Given this list of marker genes THOC2, GRAMD2B, KREMEN1, NOSTRIN, RNF19A (ring finger protein 19A, RBR E3 ubiquitin protein ligase), TRAF5, GPR160, RHBDF1, GORASP1, FOXP1, GASK1B, RICTOR (RPTOR independent companion of MTOR complex 2), SLC44A2 (solute carrier family 44 member 2 (CTL2 blood group)), MTURN, HEBP2, RAB22A, KLF3, NINJ2-AS1, PAIP1, HACD3, EEA1, NDFIP1, CLTC, KLF9, MFAP3L, KIAA1671 (KIAA1671), HTR7P1, IGSF3, CCNE1, BLNK (NCBI Gene Id 29760), FAM110C, SPRED2, ATP6V1G1, GALNT3, CHMP3, RNF103, ATP2B1, INHBB, BIK, OLFML2B, CORO2A, B3GNT2, VPS13B, CAB39L, TRAM2, RAI2, PCYT1A, C1orf115, ARRB1, DYNLL2, KRAS, TWSG1, TMEM45B (transmembrane protein 45B), SYNJ2, NUCB2, GREB1L, PRR15L, FZD4, RASD1, CPNE3, ERBB4, ZNF704, YIPF1, CAP1, GPC1-AS1, GSN, PPM1A, UTRN, BCAM (NCBI Gene Id 4455), TBC1D15 (NCBI Gene Id 64786), QKI, ORMDL1, FAM114A1, TMEM199, COL28A1, KLF7 (NCBI Gene Id 8609), VMP1, EFR3A, ATP2C2 (NCBI Gene Id 9914), STK38L, EPB41L4A, FGF13, LDLRAP1, DOP1B (DOP1 leucine zipper like protein B), ACADSB, GATA3-AS1, SAR1B, RFTN1, PAX9, GATA6, CCNYL1, PKD2, TMEM245, TTC6, FBXO25, BRWD1, CERK, ZBTB21, ZC2HC1A, SOWAHC (sosondowah ankyrin repeat domain family member C), MEF2A, ACSL1, HCAR3, FAM219B, NCEH1, GRAMD4, RAP1GAP2, DOCK11, UGDH (NCBI Gene Id 7358), HSPA2 (heat shock protein family A (Hsp70) member 2), MIPEP, PDZD2, MYO1B, ELL2, PPP2CB, PTPRJ, TJP2, CRISP3, OR7E14P, SH3D19, PSMD6, TMF1, EPS15, MAFK, TMEM135, SLC12A2, SMYD3, GTF3C1, TACC1, MALT1, CALU (calumenin), PBX1, ATP8A1 (NCBI Gene Id 10396), SYCP2, MIOS, ZNF487, MYH9, WSB2, WIPI1, YPEL3, DRAIC, KIF13B, TSPAN13, TMEM41B, PLLP, MTMR12, ATP2B1-AS1, BCDIN3D, FNTA, PLEKHA7, RHOU, PARM1, COPB2, MB, PHLDA3, ST3GAL4, ARL4C, FNBP1 (NCBI Gene Id 23048), DSCR8, CCDC160, SLC9A7, ERBB2, REEP1, USP16, EMP1, LRPAP1, TMEM41A, PLEKHS1, SMIM14, RAB20, EML1, SELENOM, TACSTD2, MIOS-DT, DRAM1, MAPK6, TBC1D13, NAXD, PHF20L1, GALNT10, FAR2P2, POGLUT3, TCF4 (NCBI Gene Id 6925), LSS, AGR2, OCLN, ULBP2, WASHC5, MAL2, CDKL5, AKTIP, SLC25A16, SGSM2, ATP2A3, SH3BP4, CEACAM6, PALM3, CDS1, SERHL2, FZD5, IDH2, TNFAIP1 (NCBI Gene Id 7126), SPAG1, LRATD2, TNFRSF10B (TNF receptor superfamily member 10b), CTNND1, SCCPDH, GOLGA3, ZNF275, S100A13, ALCAM, GAREM1, TC2N (NCBI Gene Id 123036), NATD1, TIMP3, IER2, SLC41A2, TRIB3, HOXA10, FAM20C, LIMA1, C3orf70, LITAF, DHCR24, FHIP2A, TMCO3, CHFR, GALNT7, NACC2 (NACC family member 2), GOLGA7, RAB1A, SMAP2, COPZ2, FAM234B, PIP4K2C, INPP1, NIPSNAP3B, FERRY3, RIPOR3, ABHD17C, ZDHHC7, CAB39, PCOTH, ZDHHC4, MFSD6, LFNG, PPP1CB, MID2, RFK, PHLDB2, ZNF827, IL1R1, ZNF823, ALDH3B2, MBNL1, TRAK1, SGSM1, EPB41L4B, TMEM59, FAM241A, LIMK2, MPZL2, KLHL7, DSTNP2, ARF4, RAB11A, CARD14, ST3GAL1, PI4K2B, CTNNB1, RPRM, PRICKLE2, CCDC68, ADAM9, ICA1, WLS, APELA, RIN2, CLDN4, RASL11B, GLTP, EPAS1, KCNMA1, ATP8B1, DYRK2, CDH3, SEL1L, CASP3, FGF12, SOCS6, TMTC3, NEBL, FLVCR2, LIMCH1, APLP2, RNF11, RIOK3, NXPH1, ZNF432, PGPEP1, MUC1, SEC22B, RAB2A, MIR34AHG, SQOR, ACKR3, GAB1, ASAH1, PDE8A, ENPP1, SLC9A1, DDAH2, HIP1R, GABBR2, TRIM62, FHOD1, TRAFD1, BEX4 (NCBI Gene Id 56271), BAMBI, KDELR2, COBLL1, PTPN13, LARP6, PRRT3, VPS13D, THBS1, STX12, DBI, AQP3, TMEM50B, PTGFRN, IKBKB, EHD1, MATN3, GUCD1, PPFIBP2, RUBCN, PSD3, PLEKHF2, LGALSL, NF1, ARFGEF3, INPP4A, AOX1, DIDO1, FBP1, AP1G1 (adaptor related protein complex 1 subunit gamma 1), MIA3, PMP22, PLPP5, SLC66A3, ARID5B, LOXL1, PLEKHA3, SLC4A11, NXT2, SHANK2, SIM2, BCAS1, LRP11, HACD2, CAPN9, BET1L, EPN3, SLC11A2, ZHX1, RAB27B (RAB27B, member RAS oncogene family), ARFGAP3, GMFB, FILIP1, NUDT4, SPRED1, LIPT2-AS1, TMEM178B, APOLD1, PIK3R3 (NCBI Gene Id 8503), NIPAL3, TSPAN1, AHR, ANXA3 (NCBI Gene Id 306), PDP1 (pyruvate dehydrogenase phosphatase catalytic subunit 1), WDR37, MXRA7, IKZF2, FAM210B, SMIM31, SGMS2, TIMP2, ID2, COLEC12, SPRING1, LINC01138, LNX1, PSEN1, SLC20A1, AREL1, PDXK, ZFP36, MGLL, SFMBT2, CCPG1, MACO1, STRN3, AACS, NET1, GATA2, LHFPL2, SAMD4A, DCAF5, ZBTB20, CEACAM5, EOLA1, STOM, IQSEC1, ABCC5, TTC9, HIGD1A, LPIN2, GRB10, SASH1, MTARC2, CD55, ENSG00000284634, FUT9, ADAP1, UBE2N, TBC1D30, TTC39B, TMEM87B, VAMP8, CLIC1, SDC1, YPEL5, ZFHX3, ALDH1A3, PRKCH, NFAT5, BMP7, EPB41L2, PBX3, PROM2, SWAP70, SERHL, IL13RA1, SPIRE1, PDCD6, KDELR3, CFL2, NCOA1 (nuclear receptor coactivator 1), CPEB2 (cytoplasmic polyadenylation element binding protein 2), SC5D, NCAM2, EFNB2, NIBAN1, RNF144B, VSIG10, FUCA1, TMPRSS2, OR2A1-AS1, MYCL, SH3BGRL, GPR157, ANK3, ALAD, LINC02984, EGLN3, ARHGEF37, PLBD1, PLK2, INPP5A, MIGA1, RIPOR1, MTA3, DAG1, ATP6V0D2, SAT1, GDF15, ZDHHC23, CEACAM7, GLCCI1, CTNND2, CALML5, OSBPL2, EZR, TRGC1, GOLPH3, TMEM131L, ANOS1, CCDC80, RHOA, MTUS1, PTK6 (NCBI Gene Id 5753), CYSRT1, here is a description of the gene set: from publication Creighton CJ, Massarweh S, Huang S, Tsimelzon A, Hilsenbeck SG, Osborne CK, Shou J, Malorni L, Schiff R (PMID 18794137) studied in species Homo sapiens Human Gene Set: CREIGHTON_ENDOCRINE_THERAPY_RESISTANCE_5 The effectiveness of therapies targeting specific pathways in breast cancer, such as the estrogen receptor or HER2, is limited because many tumors manifest resistance, either de novo or acquired, during the course of treatment. To investigate molecular mechanisms of resistance, we used two xenograft models of estrogen receptor-positive (ER+) breast cancer, one with and one without HER2 overexpression (MCF7/HER2-18 and MCF7 wt, respectively). Mice with established tumors were assigned to the following treatment groups: estrogen supplementation (E2), estrogen deprivation (ED), ED plus tamoxifen (Tam), all with or without the epidermal growth factor receptor tyrosine kinase inhibitor gefitinib (G). Another group received ED plus the antiestrogen fulvestrant (MCF7 wt only). Tumors with acquired or de novo resistance to these endocrine therapies were profiled for gene expression and compared with tumors in the E2 control group. One class of genes underexpressed in endocrine-resistant tumors (relative to E2-treated tumors) were estrogen inducible in vitro and associated with ER+ human breast cancers (luminal subtype). Another class of genes overexpressed in tumors with acquired resistance in both models represented transcriptional targets of HER2 signaling and was associated with ER-/HER2+ human cancers (ERBB2+ subtype). A third class of genes overexpressed in MCF7/HER2-18 tumors exhibiting de novo resistance to tamoxifen was associated with ER+ human cancers but not with estrogen-regulated genes. Thus, in response to various endocrine therapy regimens, these xenograft breast tumors shut down classic estrogen signaling and activate alternative pathways such as HER2 that contribute to treatment resistance. Over time, the molecular phenotype of breast cancer can change. The 'group 5 set' of genes associated with acquired endocrine therapy resistance in breast tumors expressing ESR1 but not ERBB2.